Given this list of marker genes HSPA8, ZNF691 (zinc finger protein 691), SLC9B2, SH3GLB1, LINS1, SERPINB2, FERRY3, IGF2R, CREG1, ZNF557, ARHGAP31, C8orf76, KCNE1, NLRC3, PJA1, TNF, NMRAL2P, DYNLL1, SLC41A2, CCRL2, PSMC1, UBE2A, ZNF879, DNAJA1, MSMO1, NFE2L2, TNFRSF10D, ADAMDEC1, HLA-A, PSMD1, KYNU, ZNF710, TUBB6, GPATCH3, ARCN1, GNPDA2, TEX10, MYO1B, TNIP1, ACOX3, PTPN12, CD63, CRIM1, UBR4, GCLM, ZNF513, CCR5, ABCC1, UNK, IL1B, CD274, SPAG9, ATL1, STARD8, TGS1, SDC4, HCP5, MED8, HLA-B, POLR2A, PTGFR, PIM1, OSGIN2, RNF13, KLLN, ZFYVE1, PLEKHB2, PSMA1, TRPC3, VCP, NPC1, CLCN7, EML4, IL1A, LRP10, SNX9, CTSB, MIR3142HG, NEU1, DUSP5, UBL5, CYP51A1, ARFGAP3, PSMD11, RHOU, TRIM21, PELO, DPH3 (diphthamide biosynthesis 3), RAB13, BCO2, TDP2, SUSD6, ITGA5, ZNF140, COLCA1, TRAV8-3, SQOR, ATP6V1H, CTSH, KCNN4, AMPD3, ALCAM, DCAF1, ATP13A3-DT, HSP90AA1, RTP4, KRT75, GSTO1, C1orf122, RAD1, MED12, DYNC1H1, RAB7A, GON4L, BANP, PIK3R5, EYA3, CTNS, C3, PSMA3, E2F6, CISH, AP3D1, DNAJB11, TNFRSF4 (TNF receptor superfamily member 4), TXLNA, STK17A, DGAT2, HMGCL, SLC1A3, GTF2A1, ERI1 (NCBI Gene Id 90459), ZNF267, MOB3C, MLLT6, NT5C1B, CPM, SLC43A3, SAV1, ZSWIM8, ADIPOR2, SH3TC2, ACTR3, TANK, EIF2B2, METTL1, MED31, STX3, POMP, ATP6V0E1, PSMA5, IL2RG, TNFRSF18, ATP6V1B2, RAPSN (NCBI Gene Id 85713), CD2BP2, HSP90AB1, PSMD14, AVIL, PSMB2, TNFAIP8, GPR35, PPP1R18, ATP6V1C1, MSC-AS1, TMEM199, SLC35F5, GPN2, LAMTOR3, MFSD2A, YIPF6, VPS9D1, RPA2, SRP54, CEP162, HIVEP2, PDXK, RSAD2, ADAM17, CFAP46, ZC3H12C, CDKN1A, TSC22D1, MFAP1, ZNF785, TM2D2, B2M, GTF3C6, CSRNP2, IRF4, MRPL27, PAFAH1B1, SERPINB8, NDUFV2, HK2, PSMB7, KMO, ZNF200, LGMN, LMAN2L, here is a description of the gene set: studied in species Homo sapiens from publication Lund R, Aittokallio T, Nevalainen O, Lahesmaa R (PMID 14607935) Th1 and Th2 cells arise from a common precursor cell in response to triggering through the TCR and cytokine receptors for IL-12 or IL-4. This leads to activation of complex signaling pathways, which are not known in detail. Disturbances in the balance between type 1 and type 2 responses can lead to certain immune-mediated diseases. Thus, it is important to understand how Th1 and Th2 cells are generated. To clarify the mechanisms as to how IL-12 and IL-4 induce Th1 and Th2 differentiation and how TGF-beta can inhibit this process, we have used oligonucleotide arrays to examine the early polarization of Th1 and Th2 cells in the presence and absence of TGF-beta after 0, 2, 6 and 48 hours of polarization. Human Gene Set: GSE2770_TGFB_AND_IL4_ACT_VS_ACT_CD4_TCELL_48H_UP Genes up-regulated in CD4 T cells activated by anti-CD3 and anti-CD28: TGFB1 and IL4 (48h) versus untreated (48h).